Given this list of marker genes TFE3, NDOR1, NCAPH2, CBLN3, CFTR, CD8A, RIMS4, NEFM, TREML2, VPS13B, NEURL1B, PRDM6, MEIOC, UPF2, PPP2R5D, C4B, NAV1, MMS19, ADCY6, PAFAH1B1, NTNG1, ACSL4, SMCR8, SEMA4F, TSPAN17, DLG4, SPRING1, PAX5, NPSR1 (NCBI Gene Id 401323), GCLC, KANK4, MEX3A, SAMD14, SHISA2, SLC35F6, EIF4B (eukaryotic translation initiation factor 4B), VANGL2, ANXA9, SHC2 (SHC adaptor protein 2), SLC37A1, MSX2, BATF3, UBE2D2, ARHGAP20, ANKRD52, TRAK2, SOCS3, SLC24A2, VWA2, C16orf90, PFKFB3, CPXM2, FUT6, MAFF, TMC7, ALPK2, DALRD3 (DALR anticodon binding domain containing 3), PNMA8B, KCNJ6, PDE1B, PPP4R3B, KIF13A, PRXL2A, CHTF8, MLEC, RBKS, CALCR, C4A, ATRX, GAS2, GTF2E1, CIR1, MLLT10, CADM3, ZDHHC3, here is a description of the gene set: Genes predicted to be targets of miRBase v22 microRNA hsa-miR-4726-3p in miRDB v6.0 with MirTarget v4 prediction scores > 80 (high confidence targets). species: Homo sapiens Human Gene Set: MIR4726_3P from publication Chen Y, Wang X (PMID 31504780)